The following is a description of a gene set: from publication Chen Y, Wang X (PMID 31504780) Mouse Gene Set: MIR_182_5P Genes predicted to be targets of miRBase v22 microRNA mmu_miR_182_5p in miRDB v6.0 with MirTarget v4 prediction scores > 80 (high confidence targets). studied in species Mus musculus, and this is the list of marker genes: Ppil1, Rab2a, Lhx3, Rev1, Tro, Adra2c, Satb2, Cdv3, Amph, Cadm3, Creb1, Taf15, Chmp1b, Prelid3b, Sox6, Ncoa4, Dcun1d3, Magi1, Fbxo42, Sdc2 (syndecan 2), Sh3bgrl2, Jmjd1c, Cd164, Pld1, Col25a1, Topbp1, Slc5a3, Mmp8, Ppp1r13b, Nr5a2, Lrrc63, Cdo1, Tmem260, Frmd5, Fmr1, Gprc5b, Foxf2, Ywhag, Arf4, Etl4, Rimbp2, Wasl, Tmem145, Elmo1, Prkacb, Rad23b, Sh3kbp1, Armc1, Rnase4, Peds1, Evi5, Ano6, Mecom, Onecut3, Frs2, Msra, Arhgef7, Rarg (retinoic acid receptor, gamma), Phf21a, Nemf, Trabd2b, Snx30 (sorting nexin family member 30), Gad2, Gxylt1 (glucoside xylosyltransferase 1), Ankrd27, Fam43a, Prune2, Grb2, Slc1a2, Tspan9, Rprd1b, Selenoi, Cited2, Nudt13, Sinhcaf, Bcat1, Pdia4, Zbtb37, Ralgps1, Fam168a, Ebf3, Adcy6, Has2, Tnfrsf1b, Fxr1, Stox2, Adam22, Rnf144b, Pygo2, Rab6b, Zfp697, Lsm14a, Nudt15, Zcchc14, Hlf, Ptprn2, Septin7, Hycc2, Clptm1l (CLPTM1-like), Lrrk1, Tbr1, Gli2, Bach2, Pcmtd1, Tns3, Mtm1, Map2k1, Cep250, Dock9, Tctn3, N4bp1, Ndrg1, Pbx2, Utp23, B4galt6, Ahcyl1, Tapt1, Cnnm3, C2cd2, Palld, Slc39a1, Zfp7, Bcl11a, Rassf1, Elavl4, Ahr, Htr1a, Zbtb41, Ednrb, Kdelr1, Lims1, Egr3, Zcchc3, Dock1, Zfp69, Cbfa2t3, Prtg, Appl1, Fam91a1, Gp1bb, Pnpla8, Cobl, Nufip2, Col5a1, Tut4, Fndc3b, Dazap2, Chst1, Cyrib, Tnfaip8, Ebf1, Mtss1, Gcnt1, Nid1, Chic1, Arhgdia, Casp2, Add3, Smad1, Phip, Zfc3h1, Cd2ap, Trp53inp1, Ildr2, Wipi2, Atad2, Psmb6, Rere, Pex5, Nudt10, Phf13, Slitrk4, Zpbp, Skil, Slc1a1, Nsd3, Creb3l1, Arhgef3, Arel1, Wdr76, Kcnj14, Denr, Clock (clock circadian regulator), Gem, Hbegf, Mtch2, Hs6st2, Onecut2, Myo1c, Epha3, Zfp36, Smim13 (small integral membrane protein 13), Bnc2, Prkce, Slc16a9, Ccny, Phf20l1, Rgs2, Vps26b, Sez6l2, Atoh8, Reps2, Igf1r, Cfh, Rapgef5 (Rap guanine nucleotide exchange factor (GEF) 5), Dok4, Stard13, Zfp36l1 (zinc finger protein 36, C3H type-like 1), Myrip, Lgi1, Camkk2, Epas1, Kdm6a, Ptprg, Dscam, Zfand4, Bnip3, Plxdc2, Slc39a9, Slco3a1, Ttyh3, Brpf3, Tarbp1, Msn, Egln1, Gys2, Tex2, Pcdh18, Mrtfb, Sp3, Pnpla2, Usp13, Vezt, Fam169a, Grhpr, Magel2, Opn3, Ntn4, Xpr1, Fgf9, Foxn2, Ralgapb, Aatk, Chl1, Chrnb1, Stag1, Ocrl, Parva, Sh3bp4, Rgs17, Braf, Gpr146 (NCBI Gene Id 80290), Ppp3r1, Ube2q2, L1cam, Klrb1b, Atp8a1, Bmt2, Slc23a2, Grhl2, B3gnt2, Cyb561, Gpr22, Aldh6a1, Zkscan17, Ell2, Retreg1, Abcb10, Cntn1, Slc2a12, Stxbp5, Gpr21, Septin9, Plppr4, Slc44a2, Adra2a, Coa7, Gna13, Cbarp, Tacc1, Ift56, Bcl2l12, Stk19, Brms1l, Cep83, Med1, Insig1, Dmxl1, Bcl2l13, Abhd18, Prdm1, Ipcef1, Thbs2, Dgkh, Dcbld1, Spin1, Bod1l, Tmem198, Ppm1k, Nf1, Coro1c, Foxo3, Tob1, Ago1, Kdelr2, Stx5a, Pcx, Cfl1, Rcor1, Yipf4 (Yip1 domain family, member 4), Lonrf2, Chmp2b, Anxa11, Gfm2, Dcun1d1, Mitf, Cadm2, Nckap1, Hook3, Olfm1, Mef2c, Camta1, Pou2f1, Flnb, Ttc9, Igsf3, Fut9, Fign, Ktn1, Vamp3, Tmem170b, Kdm2b, Fbxw11, Gabrb1, Hoxa9, Tmem50b, Ezr, Atat1, Flot1, Rasa1, Nup155, Mfap3, Prkcz, Spats2l, Dab1, Spry4, Kif19a (NCBI Gene Id 432612), Wdr5b, Fbxw7, Lcn9, Fam171a1, Pafah1b1, Cep170b, Igf1, Adgrl2, Mob1b, Actr2, 0610030E20Rik, Shc4, Nus1, Tsnax, Snap47, Ints13 (NCBI Gene Id 71177), Eif3a, Camsap2, Mak, Sorcs1, Jazf1, Aebp2, Lmtk2, Trim37, Eif5, Cdh20 (NCBI Gene Id 23836), Ncald, Cacna1b, Rac1, Nptx1, Cttn, Taf4, Sh2d1a, Ralgps2, Nrn1, Arrdc3, Zdhhc2, Rnf152, Tenm4, Baalc, Inpp5a, Rnf208, Wwc2, Tmem115 (NCBI Gene Id 97528), Fam118a, Wnt4, Nova2, Cacnb4, Dcaf4, Nuak1, Plekha7, Reck, Eif3j2, Rab10, Sesn2, Pcdh8, Fastkd2, Mast4, Pcnx1, Usp5, Rmi2, Ell (elongation factor RNA polymerase II), Gnaq, Ikzf1, Rhobtb1, Sowahb, Rwdd4a, Phyhipl (NCBI Gene Id 70911), 9330159F19Rik, Nexmif, Pdzd8, Mgat4c (MGAT4 family, member C), Tfpi, Ankrd28, Prrg3, Taf4b, Mbnl2, Fam120c, Hmgcll1, Klhl4, Tectb, Stk17b, Dock4, Tagln3, Zc3h15, Prrt3, Slc35d1